Given this list of marker genes MAPK1, GNAI1, CAMKK2, PPP1R1B, GNA14, PLCB2, OPRM1, PDE4D, PDE1B, GNG13, ADCY9, PPP2R5D, GNG3, PPP2CB, PPP3R1, PPP2R1A, PRKAR2A, CAMK2B (calcium/calmodulin dependent protein kinase II beta), PRKCD, GNGT1, PRKCA, PPP2R1B, ITPR3, ADCY8, CAMK2A, PDE1A, CAMK2D, CAMK2G, GNAT3, GNB3 (G protein subunit beta 3), PLCB4, CAMK4, GNG2, ADCY7, ADCY2, GNAI2, PDE4B, PLCB3, GNA11, ADCY6, POMC, PLCB1, AHCYL1, GNB4, CDK5, PLA2G4A, GNA15, PRKACA, PRKAR1B, GNGT2, PPP2CA, PRKX, GNG12, GNG5, PRKAR2B, PRKACG, PDYN, GNAI3, CALM1 (calmodulin 1), KPNA2, PPP3CC, ITPR2, GNG8, CREB1, GNG11, ITPR1, GNG7, PRKAR1A, GNB2 (NCBI Gene Id 96628), GNG10, GNB5, PDE4A (NCBI Gene Id 5141), CAMKK1, NBEA, PRKACB, GRK2, ADCY3, GNAL, PPP1CA, ADCY4, PPP3CB, ADCY5, PRKCG, GNAQ (G protein subunit alpha q), ADCY1, PDE1C, GNG4, PPP3CA, GNB1, PDE4C (phosphodiesterase 4C), here is a description of the gene set: Reactome Pathway: Opioid Signalling Opioids are chemical substances similar to opiates, the active substances found in opium (morphine, codeine etc.). Opioid action is mediated by the receptors for endogenous opioids; peptides such as the enkephalins, the endorphins or the dynorphins. Opioids possess powerful analgesic and sedative effects, and are widely used as pain-killers. Their main side-effect is the rapid establishment of a strong addiction. Opioids receptors are G-protein coupled receptors (GPCR). There are four classes of receptors: mu (MOR), kappa (KOR) and delta (DOR), and the nociceptin receptor (NOP). studied in species Homo sapiens part of: G alpha (i) signalling events